The following is a description of a gene set: Selected genes down-regulated during progression through benign to malignant skin tumors formed by treatment with DMBA and TPA chemicals in the two stage skin carcinogenesis model. Chemically induced mouse skin carcinogenesis represents the most extensively utilized animal model to unravel the multistage nature of tumour development and to design novel therapeutic concepts of human epithelial neoplasia. We combined this tumour model with comprehensive gene expression analysis and could identify a large set of novel tumour-associated genes that have not been associated with epithelial skin cancer development yet. Expression data of selected genes were confirmed by semiquantitative and quantitative RT-PCR as well as in situ hybridization and immunofluorescence analysis on mouse tumour sections. Enhanced expression of genes identified in our screen was also demonstrated in mouse keratinocyte cell lines that form tumours in vivo. Self-organizing map clustering was performed to identify different kinetics of gene expression and coregulation during skin cancer progression. Detailed analysis of differential expressed genes according to their functional annotation confirmed the involvement of several biological processes, such as regulation of cell cycle, apoptosis, extracellular proteolysis and cell adhesion, during skin malignancy. Finally, we detected high transcript levels of ANXA1, LCN2 and S100A8 as well as reduced levels for NDR2 protein in human skin tumour specimens demonstrating that tumour-associated genes identified in the chemically induced tumour model might be of great relevance for the understanding of human epithelial malignancies as well. species: Mus musculus Human Gene Set: HUMMERICH_SKIN_CANCER_PROGRESSION_DN from publication Hummerich L, Müller R, Hess J, Kokocinski F, Hahn M, Fürstenberger G, Mauch C, Lichter P, Angel P (PMID 16247483), and this is the list of marker genes: C3, EPHA1, ATP5F1C, SMAD4, ACSL4, MYBPH, MYL11, MAPK7 (mitogen-activated protein kinase 7), ILK, ECI1, ENO3, STMN1, GJA1, GPX3, CDC25B, SPTBN1, HP, LTBP3, TNNC2, GTF2H4, ECH1 (NCBI Gene Id 1891), PTPRF, ZYX, ATP6V0B, ID2, DSG2, PKD1, SERPING1, TNNT3, PDLIM3, MYL1, LGALS1, FHL1, PTPRS, CUX1, BCAM, COQ5, TNNI2, COL16A1, B2M, EPHB3, TCAP, GGT1, EFNB1, UBE2A, FECH, CHST11, PIK3R2, PCDH12, STK38L, NRP2, MYH4, LCMT1, PPP1CB, DES, C1QA, MYH1, ACADSB, COL6A2, FASN, PC, PDGFRA, TXNIP, DUSP14, PSEN2, RECQL5, LYZ, WWP2, LAMB2, ATP5MF, COL3A1, BMP1, TLE5, DST, HSPB7, ELOVL4, AEBP1, GPNMB, ATP5MG, MFAP4, GAA, IL11RA, MB, ACSL5, C4B, RPS6KA1, SERPINA1, RAB34, PYGM, SCP2, PRKACA, MYL9, EYA2, UBE3A, MYH8, CRAT, PRKCI, TPM2, ECSIT, HADHB, CXCL14, ECHS1, ATP5F1E